Given this list of marker genes HSPB6, NACAD, GRPEL1, NPM1, MKKS, AIPL1, HSPA1L, VBP1, DNAJB5, CLGN, CCT6A, PFDN2, HSPA5, HSPD1, CHAF1A, HSP90AB2P, PTGES3, HSPA1A, SIL1, HSPE1 (heat shock protein family E (Hsp10) member 1), CCT2, HSP90AA4P, NACA4P, CCT6B, GRPEL2, PFDN6, NUDCD2, HSP90AA1, HSPA6, SYVN1, RP2, DNAJB3, TOMM20, NACA, DNAJB2, DNAJA1, DNAJC4, CDC37L1, PFDN4, TUBB4B, TCP1, DNAJA2, HSP90B2P, CCT8L2, HEATR3, AFG3L2, HSP90AB1, HTRA2, SRSF10, TMEM67, LMAN1, DNAJB7, CANX, SRSF12, AHSA1, HSPA9, HSP90B1, PFDN5, CCT4, PDRG1, HSP90AA2P, DNAJB6, CALR3, CCT3, ERO1B, TRAP1, HSPA1B, TIMM10B, CDC37, APCS, CCAR2, ERN2, CCT8L1P (chaperonin containing TCP1 subunit 8 like 1, pseudogene), PPIA, AHSP, CCT7, SCAP, CCT5, CCDC115, DNAJA4, NAP1L4, PFDN1, DNAJB13, CALR, CRYAA, AIP, HSP90AB3P, CCT8 (chaperonin containing TCP1 subunit 8), DNAJB4 (DnaJ heat shock protein family (Hsp40) member B4), CRYAB, NUDC, CLU, SERPINH1, SSUH2, HSP90AB4P, DNAJB8, UGGT2, HYOU1, HSPA8, TAPBP, SCG5, NACA2, DNAJA3, TTC1, HSPA2, NDUFAF1, PPIB, RUVBL2, DNAJB1, DNAJB11, TOR1A, PET100, UGGT1, ERLEC1, NUDCD3, CHAF1B, HSPB1, CLPX, ERN1, SHQ1, HSP90AA5P, SPG7, HSPB2, here is a description of the gene set: Binding to an unfolded protein. species: Homo sapiens Human Gene Set: GOMF_UNFOLDED_PROTEIN_BINDING